The following is a description of a gene set: Patchy palmoplantar hyperkeratosis species: Homo sapiens Human Gene Set: HP_PATCHY_PALMOPLANTAR_HYPERKERATOSIS A focal type of palmoplantar keratoderma in which only certain areas of the palms and soles are affected., and this is the list of marker genes: DSP, GJB3, TRPV3, GJB4, GJA1, KDSR